The following is a description of a gene set: studied in species Homo sapiens Genes that have low expression in mammary tumors of solid nodular histology. from publication Hollern DP, Swiatnicki MR, Andrechek ER (PMID 29346386) Human breast cancer has been characterized by extensive transcriptional heterogeneity, with dominant patterns reflected in the intrinsic subtypes. Mouse models of breast cancer also have heterogeneous transcriptomes and we noted that specific histological subtypes were associated with particular subsets. We hypothesized that unique sets of genes define each tumor histological type across mouse models of breast cancer. Using mouse models that contained both gene expression data and expert pathologist classification of tumor histology on a sample by sample basis, we predicted and validated gene expression signatures for Papillary, EMT, Microacinar and other histological subtypes. These signatures predict known histological events across murine breast cancer models and identify counterparts of mouse mammary tumor types in subtypes of human breast cancer. Importantly, the EMT, Adenomyoepithelial, and Solid signatures were predictive of clinical events in human breast cancer. In addition, a pan-cancer comparison revealed that the histological signatures were active in a variety of human cancers such as lung, oral, and esophageal squamous tumors. Finally, the differentiation status and transcriptional activity implicit within these signatures was identified. These data reveal that within tumor histology groups are unique gene expression profiles of differentiation and pathway activity that stretch well beyond the transgenic initiating events and that have clear applicability to human cancers. As a result, our work provides a predictive resource and insights into possible mechanisms that govern tumor heterogeneity. Human Gene Set: HOLLERN_SOLID_NODULAR_BREAST_TUMOR_DN, and this is the list of marker genes: ICAM1, TSPAN11, PDPN, DGKH, ANKRD44, TRIM35, VASH2, COL2A1, P4HA2, GJA1, BMP2, RBMS3 (RNA binding motif single stranded interacting protein 3), AQP1, IFITM1, PANX1, HAS2, RYR1, NID1, ADAMTS9, IL1R2, LDAF1, SPARC, TPST1, RALGPS2, TWIST1, ENPP2, IGFBP4, LRRC8C, GLI3, PTPRS